Given this list of marker genes Nolc1, Crebbp, Esr1, Tbp, Tcf4, Foxf2, here is a description of the gene set: Mouse Gene Set: GOMF_TFIIB_CLASS_TRANSCRIPTION_FACTOR_BINDING species: Mus musculus Binding to a general RNA polymerase II transcription factor of the TFIIB class, one of the factors involved in formation of the preinitiation complex (PIC) by RNA polymerase II.